The following is a description of a gene set: studied in species Homo sapiens Reactome Pathway: Defective CYP11B1 causes AH4 part of: Metabolic disorders of biological oxidation enzymes Cytochrome P450 11B1, mitochondrial (CYP11B1) possesses steroid 11-beta-hydroxylase activity which can convert 11-deoxycortisol to cortisol. 11-beta-hydroxylase deficiency is one of the main causes of congenital adrenal hyperplasia (CAH) (5-8%), second only to 21-hydroxylase deficiency which accounts for more than 90% of CAH. Defects in CYP11B1 can cause Adrenal hyperplasia 4 (AH4; MIM:202010), a form of congenital adrenal hyperplasia which is a common recessive disease due to failure to convert 11-deoxycortisol to cortisol. This impaired corticosteroid biosynthesis results in androgen excess, virilization and hypertension., and this is the list of marker genes: CYP11B1